Given this list of marker genes Zfp644, Chd7, Garnl3, Rnf24, Plagl2, Mbtd1, F3, Ppp1r15b, Nck1, Tardbp, Fzd3, Zic2, Ankrd12, Gngt1, Ewsr1, Lmcd1, Traf3, Cacna1d, Calcr, Usp7, Fzd7, Rbm46, Dnaja2, Tshz3, Sec62, Malt1, Adam22, Mideas, Nek3, Zfp503, 2810021J22Rik, Tnfsf13b, Slc35f1, Med19, Slc25a46, Med13, Rictor, Lsm14b, Pou3f2, Cpd, Akap12, Ccdc117, Dip2b, Tapbp, U2surp, Pbrm1, Cnr1, Cul4b, Zbtb44, Teddm1b, Tra2b, Enc1, Msi2, Tiam1, BC061237, Aldh1a3, Cts3, Nsun6, Trim9, Serpina3f, Saysd1, Hycc2, Sh3bp5, Pptc7, Hmgcl, Kmt2a, Zfp672, Strn, Ccdc73, Tsc1, Slc12a1, Mcmbp, Cfap300, Pcnp, Socs7, Gdpd1, Strn3, Thap11, Khdrbs3, Prkaa2, Sbds, Insyn2b, Thsd7b, Baz2a, Celf5, Knstrn, Cib1, Tbc1d2b, Oser1, Stag1, Mbnl1, Cdca4, Slc25a51, Hcn1, Ostm1 (NCBI Gene Id 74109), Jarid2, Stk36, Slc33a1, Tmem170b (transmembrane protein 170B), Smr2l, Postn, Bspry, Hs6st2, Epc1, B230217C12Rik, Faf2, Marchf1, Gm10375, Gnai3, Abhd17b, Mdga2, Dnmt1, Rspo1, Isl1, Cnot6, Rbm27, Arrdc3, Mybl1, Dock9, Rasal2, Xpo7, Clca2, Mettl21e, Cep70, 1700001F09Rik, Lrit2, Eif4g2, Adam10, Vstm2a, Chd6, Tob1, Smad7, Ctdspl2, Lamtor5 (NCBI Gene Id 68576), Runx1, Phlpp1, Gm5800, Eid1, Gm10377 (predicted gene 10377), here is a description of the gene set: from publication Chen Y, Wang X (PMID 31504780) Mouse Gene Set: MIR_703 Genes predicted to be targets of miRBase v22 microRNA mmu_miR_703 in miRDB v6.0 with MirTarget v4 prediction scores > 80 (high confidence targets). species: Mus musculus